Given this list of marker genes Sprr1a, Krt86, Lce1a2, Sprr2h, Krt2, Krt90, Krt82, Sprr2e, Krt16, Tmem79, Gm5414, Gprc5d, Lce1g, Cyp26b1, Sprr4, Krt74, Krt84, Krt17, Krt7, Sprr3 (small proline-rich protein 3), Sfn, Kazn, Sprr2k, Cers3, Krt73, Krt75, Ivl (NCBI Gene Id 68605), Sprr2d, Krt85, Ppl, Evpl (NCBI Gene Id 14027), Krt1, Krt77 (NCBI Gene Id 406220), Krt80, Tgm1, Gm5478, Krt79, Krt81, Tgm3, Cdsn, Il1a, Krt5, Krt76, Krt71, Krt4 (keratin 4), Pphln1, Sprr2i, Krt6a, Sprr2f, Sprr2b, Krt78, Loricrin, Krt83, Krt87, Hrnr, Abca12 (ATP-binding cassette, sub-family A member 12), Sharpin, Cnfn, Sprr1b, Krtap6-5 (keratin associated protein 6-5), Sprr2g, Cdh3, Krt72, Krt6b, here is a description of the gene set: Mouse Gene Set: GOBP_KERATINIZATION The process in which the cytoplasm of the outermost cells of the vertebrate epidermis is replaced by keratin. Keratinization occurs in the stratum corneum, feathers, hair, claws, nails, hooves, and horns. studied in species Mus musculus